The following is a description of a gene set: The series of molecular signals initiated by interferon-gamma binding to its receptor on the surface of a target cell, and ending with the regulation of a downstream cellular process, e.g. transcription. Interferon gamma is the only member of the type II interferon found so far. studied in species Mus musculus Mouse Gene Set: GOBP_TYPE_II_INTERFERON_MEDIATED_SIGNALING_PATHWAY, and this is the list of marker genes: Pparg, Dnaja3, Irgm1, Jak1, Parp9, Irgm2, Stat1, Ifng, Ptpn2, Trp53, Jak2, Arg1, Txk, Parp14, Nlrc5, Irf1, Ifngr1, Med1, Igtp, Tyk2, Cdc37, Hpx, Otop1